The following is a description of a gene set: electronically inferred by orthology from the curated human pathway studied in species Mus musculus Reactome Pathway: Chondroitin sulfate/dermatan sulfate metabolism This event has been computationally inferred from an event that has been demonstrated in another species.<p>The inference is based on the homology mapping from PANTHER. Briefly, reactions for which all involved PhysicalEntities (in input, output and catalyst) have a mapped orthologue/paralogue (for complexes at least 75% of components must have a mapping) are inferred to the other species. part of: Glycosaminoglycan metabolism, and this is the list of marker genes: Chsy1, Chst15, Glb1l2, Csgalnact1, Dsel, Glb1l3, Hyal4, Bgn (NCBI Gene Id 12111), Chst14, Dse, Dcn, Hyal1 (hyaluronoglucosaminidase 1, NCBI Gene Id 15586), Csgalnact2 (chondroitin sulfate N-acetylgalactosaminyltransferase 2), Hexa, Hexb, Chst12, Chsy3, Chst13, Ids (NCBI Gene Id 15931), Ust, Chst9, Cspg5, Glb1l